Given this list of marker genes Eef1a1, Eef2, Eef1g, here is a description of the gene set: electronically inferred by orthology from the curated human pathway This event has been computationally inferred from an event that has been demonstrated in another species.<p>The inference is based on the homology mapping from PANTHER. Briefly, reactions for which all involved PhysicalEntities (in input, output and catalyst) have a mapped orthologue/paralogue (for complexes at least 75% of components must have a mapping) are inferred to the other species. species: Mus musculus Reactome Pathway: Eukaryotic Translation Elongation part of: Translation